The following is a description of a gene set: studied in species Homo sapiens Reactome Pathway: Essential pentosuria Essential pentosuria, the excretion in the urine of high levels of L-xylulose, is a benign autosomal recessive trait found in Ashkenazi Jewish and Lebanese populations. It is due to mutations that inactivate DXCR (L-xylulose reductase) and thus prevent the conversion of L-xylulose to xylitol in the glucuronate pathway. part of: Diseases of carbohydrate metabolism, and this is the list of marker genes: DCXR